Given this list of marker genes LRRN4, EPS8L1, CBLN2, KLK7, MIR31HG, SLC7A4, LINC00922, PTPRQ, HAS1, PLA2G2A, MKX, KLK11, KLK5, ALKAL2, EPCIP, PRR15-DT, C1orf53, GSDMA, MAL2, C3, ATP7B, LINC01239, CRB2, KREMEN2, IGFBP5, NXNL2, ITLN1, SLC4A4, C1QL1, BDKRB1, MPPED2-AS1, NRG4, LINC02643, RSPO1, LINC01018 (NCBI Gene Id 255167), GADL1, NHERF4, CFB, DAW1, PRG4, NEU4, KRT5, LRAT, TNFRSF11B, TGM1, LINC01638, KCTD8, KRT7, CERS3-AS1, CST6, SBSPON, MSLN, LINC02331, SCEL, ABCA12, HSD17B6, GSG1L, CLDN1, RHPN2, CA9, UBXN10, ENSG00000268686, EPGN, ZFP42, CDH3, MYRF, NMU, EFEMP1, UPK1B, RARRES1, WT1, CFTR, LRP2, PHYHIP, FSHR, CDON, SPRR2F, LINC01266, NPHS1, IGHG4, WNT2B (NCBI Gene Id 7482), SIM1, PPP4R4, CCNYL1, SLPI, TNFRSF8, FAM110C, UPK3B, FMO1, ECRG4, KCTD4 (NCBI Gene Id 386618), FAM83A, CPA4, CPB1, RAET1E, CHAC1, ENSG00000254951, PRR15, FYB2, SFRP5, PDZRN4, SPRR2B, CARNS1, MKRN9P, GRB7, BNC1, PDZK1IP1, GFPT2, PLEKHH2, TRHDE-AS1, ADAMTS3, here is a description of the gene set: Marker genes curated from the annotated cluster as represented in the Descartes Human Gene Expression During Development database. from publication Cao J, O'Day DR, Pliner HA, Kingsley PD, Deng M, Daza RM, Zager MA, Aldinger KA, Blecher-Gonen R, Zhang F, Spielmann M, Palis J, Doherty D, Steemers FJ, Glass IA, Trapnell C, Shendure J (PMID 33184181) Human Gene Set: DESCARTES_FETAL_HEART_EPICARDIAL_FAT_CELLS studied in species Homo sapiens The gene expression program underlying the specification of human cell types is of fundamental interest. The study authors generated human cell atlases of gene expression and chromatin accessibility in fetal tissues. For gene expression, the study authors applied three-level combinatorial indexing to >110 samples representing 15 organs, ultimately profiling ~4 million single cells. The study authors leveraged the literature and other atlases to identify and annotate hundreds of cell types and subtypes, both within and across tissues. Our analyses focused on organ-specific specializations of broadly distributed cell types (such as blood, endothelial, and epithelial), sites of fetal erythropoiesis (which notably included the adrenal gland), and integration with mouse developmental atlases (such as conserved specification of blood cells). These data represent a rich resource for the exploration of in vivo human gene expression in diverse tissues and cell types.